The following is a description of a gene set: part of: Gene expression (Transcription) Reactome Pathway: RNA Polymerase I Transcription RNA polymerase (Pol) I (one of three eukaryotic nuclear RNA polymerases) is devoted to the transcription of the ribosomal DNA genes, which are found in multiple arrayed copies in every eukaryotic cell. These genes encode for the large ribosomal RNA precursor, which is then processed into the three largest subunits of the ribosomal RNA, the 18S, 28S, and 5.8S RNAs. In human cells the rDNA gene clusters are localized on the short arm of the five pairs of the acrocentric chromosomes. The rRNA promoter has two essential and specially spaced sequences: a CORE element and an upstream control element (UCE, also called UPE). The CORE element of the human promoter overlaps with the transcription start site, extending from 20 to 45, and is required for specific initiation of transcription. <br> The polymerase is a multisubunit complex, composed of two large subunits (the most conserved portions include the catalytic site that shares similarity with other eukaryotic and bacterial multisubunit RNA polymerases) and a number of smaller subunits. Under a number of experimental conditions the core is competent to mediate ribonucleic acid synthesis, in vivo however, it requires additional factors to select the appropriate template. In humans the RNA transcript (45S) is approximately 13,000 nucleotides long. Before leaving the nucleus as assembled ribosomal particles, the 45S rRNA is cleaved to give one copy each of the 28S rRNA, the 18S rRNA, and the 5.8S rRNA. Equal quantities of the three rRNAs are produced by initially transcribing them as one transcript. studied in species Homo sapiens, and this is the list of marker genes: MTA2 (metastasis associated 1 family member 2), GTF2H1, CHD4, POLR1A, CAVIN1 (caveolae associated protein 1), ERCC2, H2AC4, H2AC20, POLR1F, TAF1A (NCBI Gene Id 9015), POLR1C, MBD2, RNA45S5, RRN3, GATAD2A, H2BC13, POLR2K, GATAD2B, H3C15, H2BC12, GTF2H5, ERCC3 (ERCC excision repair 3, TFIIH core complex helicase subunit), ERCC6, H2AC7, H2BC12L, TAF1B (NCBI Gene Id 9014), RBBP7, UBTF, TBP, MAPK3, H2AC14, POLR1B, H2AJ, CBX3, CCNH, HDAC2, EHMT2, MTA1, RBBP4, H2AZ2, MNAT1, H2AB1, H2BC5 (H2B clustered histone 5), TTF1, POLR2H, H2AC6, H2BC15, GTF2H4, H4C1, H2BC21, H2BC14, POLR1G, H2BC9, H2AC18, H3C1, H2BC17, H2AX, POLR2L, 45S pre-rRNA gene, CHD3, POLR2F, H2BC26, MTA3, POLR1H, HDAC1, H3-3A, H2BC1, KAT2B, MBD3, POLR2E, H2BC4, KAT2A, TAF1D, H2BC11, GTF2H2, POLR1E, TAF1C, CDK7, GTF2H3 (general transcription factor IIH subunit 3), POLR1D, H2BC3